The following is a description of a gene set: Neighborhood of CDC2L5 cell division cycle 2-like 5 (cholinesterase-related cell division controller) in the MORF expression compendium studied in species Homo sapiens Neighborhood of CDC2L5 Human Gene Set: MORF_CDC2L5, and this is the list of marker genes: ESR1, AMFR, MYO9B, SLC30A3, IRF2, PPP5C, GRIP2, PCF11, WDR62, ENTREP1, MT4, TAF2, JRK, CEP350, TAF5L, IMPA1, CHD3, ZNF500, EP400, ATP6V0A2, OARD1, FDXR (ferredoxin reductase), FANCG, RAP1A, SEC31A, PAX9, SLC2A1, ATP6V1B1, CLPX, HNRNPL, FNTB, OSR1, RPS6KB2, PCBP3, DPT, PIGB, SCAMP1, PIGR, SFSWAP, KANK2, SPEF1, PLEKHB1, SLC22A24, SIK3, AFF2, TBC1D22A, TTI1, DDX11, CAMK2G, RASSF1, HTR7, TTLL5, CLP1, NFYB, FRYL, CSTF3, ARC (activity regulated cytoskeleton associated protein), SLC12A4, RUNX1, TM4SF5, CNOT9, KIAA0586, NEK9 (NCBI Gene Id 91754), NFRKB, BTD, PIAS2, MC2R, BCL2, GALNT2, PAX8, SS18, CPSF4, JAK3, SPRN, ECE2, BRD1, EXTL3, B4GALT3, TLN2, SSTR5, NR2C1, KLHL18, ATRX, AGPS, SLC24A1, GLE1, TPR, TBX5, ITIH4, CRYAA, SMC5, BPHL, PSMF1, KRT33A, EML3, COLQ (collagen like tail subunit of asymmetric acetylcholinesterase), ERCC2, PIGF, SLC30A1, ROCK1, ZDHHC18, MSX1, ZKSCAN3, DAPK2, SLC25A11, UTRN, TP53BP1, PHF21A, MR1, SEZ6L, TMEM94 (NCBI Gene Id 9772), DOK1, NKRF, INPP5E, HTR4, TMEM11, GSK3B, PCGF1, TTC22, GRIK5, NUMB, LEPROTL1, PAFAH1B1, MPP2, BAHD1, IKBKE, PAXIP1, IPCEF1, SH2B1, AQP5, CDK13, GPATCH8, RERE, DIMT1, ZNF592, NRTN, PEX6, PRELID3A, PIK3CB, MTX1, RBBP8, CHD9